The following is a description of a gene set: To investigate the relationship between Barrett's esophagus (BE) and esophageal adenocarcinoma (EAC), we determined gene expression profiles of discrete pathological stages of esophageal neoplasia using a sequence-verified human cDNA microarray. Fifty one RNAs, comprising 24 normal esophagi (NE), 18 BEs, and nine EACs were hybridized to cDNA microarrays. Five statistical analyses were used for the data analysis. Genes showing significantly different expression levels among the three sample groups were identified. Genes were grouped into functional categories based on the Gene Ontology Consortium. Surprisingly, the expression pattern of BE was significantly more similar to EAC than to NE, notwithstanding the known histopathologic differences between BE and EAC. The pattern of NE was clearly distinct from that of EAC. Thirty-six genes were the most differentially modulated, according to these microarray data, in BE-associated neoplastic progression. Twelve genes were significantly differentially expressed in cancer-associated BE's plus EAC (as a single combined tissue group) vs noncancer-associated BE's. These genes represent potential biomarkers to diagnose EAC at its early stages. Our results demonstrate that molecular events at the transcriptional level in BE are remarkably similar to BE's-associated adenocarcinoma of the esophagus. This finding alarmingly implies that BE is biologically closer to cancer than to normal esophagus, and that the cancer risk of BE is perhaps higher than we had imagined. These findings suggest that changes modulated at the molecular biologic level supervene earlier than histologic changes, and that BE is an early intermediate stage in the process of EAC. Genes down-regulated in esophageal adenocarcinoma (EAC) and Barret's esophagus (BE) relative to normal esophagi. species: Homo sapiens Human Gene Set: WANG_BARRETTS_ESOPHAGUS_AND_ESOPHAGUS_CANCER_DN from publication Wang S, Zhan M, Yin J, Abraham JM, Mori Y, Sato F, Xu Y, Olaru A, Berki AT, Li H, Schulmann K, Kan T, Hamilton JP, Paun B, Yu MM, Jin Z, Cheng Y, Ito T, Mantzur C, Greenwald BD, Meltzer SJ (PMID 16449976), and this is the list of marker genes: SLURP1, CSTA, VAT1, OBSL1, RELN, TRIM29, KRT1, ST3GAL4, SPRR2C, NFRKB, SULT2B1, ANXA8, CBR3, ECM1 (NCBI Gene Id 1893), ARL4D, TPD52L2, CSTB, CRABP2, PPL, KRT4, RARG, CDA, KRT6A, PGD, PAX9, S100A2, LGALS7, EMP1, NEDD9, ANXA1, MAFG, MAL, ALOX12, GPX3, LY6G6C (NCBI Gene Id 80740), SERPINB3, FDXR